The following is a description of a gene set: Each infectious agent represents a unique combination of pathogen-associated molecular patterns that interact with specific pattern-recognition receptors expressed on immune cells. Therefore, we surmised that the blood immune cells of individuals with different infections might bear discriminative transcriptional signatures. Gene expression profiles were obtained for 131 peripheral blood samples from pediatric patients with acute infections caused by influenza A virus, Gram-negative (Escherichia coli) or Gram-positive (Staphylococcus aureus and Streptococcus pneumoniae) bacteria. Thirty-five genes were identified that best discriminate patients with influenza A virus infection from patients with either E coli or S pneumoniae infection. These genes classified with 95% accuracy (35 of 37 samples) an independent set of patients with either influenza A, E coli, or S pneumoniae infection. A different signature discriminated patients with E coli versus S aureus infections with 85% accuracy (34 of 40). Furthermore, distinctive gene expression patterns were observed in patients presenting with respiratory infections of different etiologies. Thus, microarray analyses of patient peripheral blood leukocytes might assist in the differential diagnosis of infectious diseases. Human Gene Set: GSE6269_E_COLI_VS_STAPH_AUREUS_INF_PBMC_DN studied in species Homo sapiens from publication Ramilo O, Allman W, Chung W, Mejias A, Ardura M, Glaser C, Wittkowski KM, Piqueras B, Banchereau J, Palucka AK, Chaussabel D (PMID 17105821) Genes down-regulated in comparison of peripheral blood mononuclear cells (PBMC) from patients with acute E. coli infection versus PBMC from patients with acute S. aureus infection., and this is the list of marker genes: ITGAM, ITGAX, FKBP2, APLP2, CYTH4, TKFC, IGHG1, HSPA5 (heat shock protein family A (Hsp70) member 5), ARPC1A, RNASE3, APOBR, STX3, PSTPIP1, SLC36A1, TMCO3, RAB27A, SLC25A44, PDIA6, RNF19B, PTPRE, F5, SDF4 (stromal cell derived factor 4), MAF, DHRS7, FUT7, PISD, CDC42EP3, GNA15, MYO1F, CPD, PDIA5, IER3, FLOT2, NBEAL2, TPRA1, GAS7, SIRPA, NIBAN1, CLEC5A, SIRT7, TFE3, IL1R2, SLC26A6, MGAM, GALNS, TSPAN4, INPPL1 (NCBI Gene Id 3636), MANSC1, CXCL2, RPN2, NDST1, STAT3, APMAP, LPAR2, PLP2, HLA-DQA1, TBK1, LTB4R, NAALADL1, IL1R1, F11R (NCBI Gene Id 50848), RAB5IF, ELOVL1, TLR2, CAPG, TM9SF1, PNPLA6, CYP1B1, RAF1, ASL (NCBI Gene Id 435), OSBPL2, RAC1 (NCBI Gene Id 5879), LYZ, GAPDH, SH3TC1, SLC15A3, NR1H2, PDXK, EREG, IRAK1 (NCBI Gene Id 3654), PDLIM7, CLEC3B (C-type lectin domain family 3 member B), CDS2, ZNF668, NPDC1, CALU, MMP9 (matrix metallopeptidase 9), SRRT, PTX3, ADAM8, ZSWIM8, IMPDH1, IMPA2, MAN2A2, ANG, FBXL15, IGF2R, EIF4G1, PAM, CLMN (calmin), P4HB, PCNX1, CYP4F3, LIMK2, GPAA1, ADAM9, ZYX, PRRG4, CKAP4, POR, NRG1, YIPF3, CC2D1A, ICAM1, ELL, CLN3, CES1, MMP8, SH3GLB1, TK2, GRN, NT5DC2, LPCAT3, GBA1, CSF3R, CR1, NOMO1, SIRPAP1, PRKCD, ERO1A, TOR3A, RGS2, HOMER3, ARF1, SEC24D, CHPF2, NEU1, HOXA9, ADRM1, TGOLN2, CPT1A, ALCAM, FADS1, COPE, S100A9, MYDGF, EOGT, LGALS3, PHC2, PLXND1, TNFRSF10C, PPP4R1, FHOD1, NAGPA, CXCL3, ANPEP, BCKDK, SEL1L3, JAG1, PCOLCE2, MYO5A, HIP1, PYGL, S100A6, RRBP1, LAMP1, CTSD, ATP6V0B, IDS, HCAR3, FSCN1, KMT5AP1, STAB1, TPD52L2, CD14